The following is a description of a gene set: from publication Chen Y, Wang X (PMID 31504780) Human Gene Set: MIR9983_3P studied in species Homo sapiens Genes predicted to be targets of miRBase v22 microRNA hsa-miR-9983-3p in miRDB v6.0 with MirTarget v4 prediction scores > 80 (high confidence targets)., and this is the list of marker genes: STIM2, GRIP1, FBXL4, TNFSF11, G3BP1, COL5A1, PLA2G12A, SLC17A6, PBX3, CTDSPL2, PAX6, LRIG3, ETV6, ZNF470, MIER3, GTF2A1, CBX7, PHIP, ZNF570, PITPNB, STOX2, ZNF426, UGT2B15, CCR6, MAST4, PAK3, APCDD1, AS3MT, SCAI, TENT5A (NCBI Gene Id 55603), LEPROTL1, ARID1B, SPIN2B, PPCS, TYW1, NRXN3, KLHL32, PDE12, NR4A2, VPS36, VXN, NOL4, WDR35, SCML4, VASH2, IFI44L, SIAH1, TIAL1, DCAF4L1, LPP, RRAGD, MED26 (NCBI Gene Id 9441), ACTN1, LDB3, ZNF462, LRRC2, AHDC1, TCF20, RNF217, CADM2, TAB1, TYW1B, DLK1, KIAA0232 (NCBI Gene Id 9778), ARID3A, SBK1, NEXMIF, SBNO1, CALM1, LAMA4, ZNF516, LRRC4C, YIPF6, IFT80, NIPBL, GLCCI1, ETV1, MGLL, MBNL1, UNC13D, GNAQ, TSHZ1 (NCBI Gene Id 791257), ATG14, CACNA1B, OXR1, CASP6 (NCBI Gene Id 839), MATR3, POLH, PDZRN4, OSTM1, POU2F2, ZNF281, RASSF6, RARRES1, STEAP2, ZMIZ1, NUP50 (nucleoporin 50), GABBR2, COL8A1, NEDD1, PHF3, SGCD, THUMPD1, PIGK, CYP20A1, NUP43, ZFHX3, BACH2, DAAM1, ZBTB10, QKI (NCBI Gene Id 9444), TOMM40 (translocase of outer mitochondrial membrane 40), TAOK3 (TAO kinase 3), KIF1B, SLC25A46, CREBRF, ARHGEF10L, TMEM65, PALM2AKAP2, RGS17, C6orf47, KCNAB1, ARL10, MDM4, RUNX1, RPS6KA5, CRB1, ITPR1, DENND5B, FRYL, SLC13A1, CKAP4, PCDH10, ERAP1, ROCK1, HIPK2, TAOK1, PSD3 (NCBI Gene Id 55358), IGF1, CACNB4, APC, PIK3R1, HS1BP3, YWHAB, SHISA9, CRIM1, DENND10, HOXA5, EP300, MINDY2, RBFOX1, PHF21A, GRIA4, NALF1, KLHL28, NEUROD2, PCDH17, C3orf38, CSMD2 (NCBI Gene Id 282565), PRCP, SDAD1, PKHD1, AGO3, AKAP10, GPR161, TBL1XR1 (NCBI Gene Id 81612), ZFP36L2, HBS1L, RBMS3, BPTF, IMPG2, EIF4G3, SMAD4, CDH12, CTC1, ZXDA, SOX4, MAPRE1, MEGF11, RGS5, ZNF704 (NCBI Gene Id 84737), SEC14L1, KCTD1, FTHL17, NUS1, TMEM168, TNFRSF9, ICAM4 (intercellular adhesion molecule 4 (Landsteiner-Wiener blood group)), LIN54 (lin-54 DREAM MuvB core complex component), MFAP3L, TMEM245, OTUD7B, ARID4A, IKZF2, GK5, IKZF5, HNRNPR, MED13L, FOXP2 (forkhead box P2), CREB5, XIAP, HIC2, KCNB1, RAB3B, C11orf54, MAPK1, MYCBP2, XKR4, SSH2, DNAJC13, JADE1, KLHL31, SORBS2, DNAJB5, FNDC5, HOXC10, GDE1, RPS6KB1, BEND7, PPP1R12A, ADCY2, ZFP1, HAPLN1, SCN8A, SUGP2, TRIM49C, LYRM7, PWWP3B, GANC, NFIB, DAB2IP, TSHZ2, RIMS2, UNC80 (NCBI Gene Id 84540), ALOX12B, ZBTB20, SESTD1, ACVR1C, REP15, CXXC4, ANKS1B, ZMAT3, DDHD1, ATF7IP, SPN, CELF2, ZFP36L1, LANCL1, TRIP13, F13A1, METTL2A, ETS1, VAMP1, NRG2, PMEPA1, GK, RUNX1T1, ZFHX2, PABPC5, RBAK, OTX1, REEP1, CCDC43, WWC1, CNTNAP2, ANKRD55, ADAM10, PCDH7, AMOTL2, VGLL4, POU3F1, NPEPPS, PBX1, KLHL5, MBNL3, U2SURP, LHX2, DSE, SMIM9, HDAC9 (NCBI Gene Id 9734), BEAN1, YPEL5, WDR5B, HIPK1, REL, CAMK1D, ANKRD12, SEMA6A, KLF7, FCHO2, ELK3, PGRMC2, TENT4B, CIB2, FMR1, HCN1, DSTYK, CTH, TERF2, ETNK1, NFIC, USP9X, AMMECR1, MEF2A, VCP, MARVELD3, PCLO, RBMS1, MINAR1, FUT9 (NCBI Gene Id 10690), ELF1, CADM1 (NCBI Gene Id 337934), KLF17, CBLIF, SNTN, CHMP2B, DCAF5, PIGBOS1, EBF1, DENND1B, CEP41, JARID2, CERS6, CAMTA1, VPS26A, RAB23, MTF1, S1PR3, FAT3, FKBP5, ST6GAL2, PRKCB, GALNT1, NRXN1, OTUD6B, CNTN4, INHBC, CBLB, ELAVL4, COL1A1, SPIN2A, CELF1, CBX4, GRM5, ZBTB34, IL27RA, PRR11, CAMK2N1, USP6NL (USP6 N-terminal like), LARP1, INO80D, TENM1, ZMAT2, KIF26A, SUN2, YIPF5, TNRC6C, CAMK4, FAM210B, POLR3E, XIRP2, UQCRHL, ETV5 (NCBI Gene Id 2119), UBASH3B, ERMN, PKNOX1, C2orf88, SATB1, CCDC170, CLOCK (NCBI Gene Id 9575), C1RL, APOOL, STAT5B, LMNA, CFAP68, F2R, SOS2, LIMS1, MEPE, LINGO2, BRD3, CACNG2, FXR1, ACTN4, WDR59, CDCA2 (NCBI Gene Id 191589), ARK2C, ZNRF1, MAN1A2, TASOR2 (NCBI Gene Id 54906), CTBP2, DCLRE1C, MMP19, GLUL, IL17RB (interleukin 17 receptor B), BICD2, RYR2 (ryanodine receptor 2), TNRC6B, ACSL4, ZNF385D, SLC9A7, PIAS4, WNT5A (Wnt family member 5A), GTF2H5, MRPL44, AUTS2, ZBTB4, TMEM201, WNK3, CD2AP, KANK4, TIAM2, MED12L, CLNK, GNRHR, RNF212B, SCARA5, CPT1A, TRIM49, PUM1, PTP4A1, SLC39A14, ADD3, PGR, IVD, TOX, SBF2, SLC25A25, NEBL, FST, ARL17A, ATP2B3, KLHL24, NAA35, DGKH, USP13, IFFO2, MAP3K13, NCOA1, TCF4, USP49, ATRN, PDS5A, ZNF678, SGMS1, MATN2 (NCBI Gene Id 4147), GFRA2, CDC42EP3, PHAX, FHIP2A, IGIP, DUSP10, PRRG2, POLR2E, NR2C2, DNMT3A, CHRNA3, PLAGL2, PIEZO2, MME, PDCD6, UNC13A, CNN3, SNRNP27 (small nuclear ribonucleoprotein U4/U6.U5 subunit 27), UNC5D, MED29